The following is a description of a gene set: studied in species Homo sapiens Human Gene Set: GOBP_POSITIVE_REGULATION_OF_GLUCOSE_METABOLIC_PROCESS Any process that increases the rate, frequency or extent of glucose metabolism. Glucose metabolic processes are the chemical reactions and pathways involving glucose, the aldohexose gluco-hexose., and this is the list of marker genes: DYRK2, GCG, ARPP19, PPP1R3B (NCBI Gene Id 79660), ADCY10, ACTN3, PHKA1, PPARA, MIR210, PPP4R3B, DDB1, KAT2A, AKT2, SIRT1, KAT2B, HMGB1, EPM2AIP1, PPARGC1A, SLC45A3, PTPN2, PPP1R3G, IRS2, PTH, PPP1CA, INSR, PPP1R3E, SORBS1, PRKACA, DGAT2, WDR5, IGF1, AKT1, GPLD1, GCK, PRKAG3, PHKG2, INS, IGF2, NNMT, MIR103A1, SIRT7, IRS1, CRY1, PMAIP1, PRKAG2, PRKAG1, MIR107, PPP4R3A, FOXO1